The following is a description of a gene set: Human Gene Set: GOBP_POSITIVE_REGULATION_OF_CD8_POSITIVE_ALPHA_BETA_T_CELL_ACTIVATION species: Homo sapiens Any process that activates or increases the frequency, rate or extent of CD8-positive, alpha-beta T cell activation., and this is the list of marker genes: LILRB4, CBFB, NCKAP1L, RUNX3, HLA-E, XCL1, HLA-A, RUNX1